The following is a description of a gene set: Human Gene Set: DESCARTES_FETAL_EYE_PDE11A_FAM19A2_POSITIVE_CELLS Marker genes curated from the annotated cluster as represented in the Descartes Human Gene Expression During Development database. from publication Cao J, O'Day DR, Pliner HA, Kingsley PD, Deng M, Daza RM, Zager MA, Aldinger KA, Blecher-Gonen R, Zhang F, Spielmann M, Palis J, Doherty D, Steemers FJ, Glass IA, Trapnell C, Shendure J (PMID 33184181) species: Homo sapiens The gene expression program underlying the specification of human cell types is of fundamental interest. The study authors generated human cell atlases of gene expression and chromatin accessibility in fetal tissues. For gene expression, the study authors applied three-level combinatorial indexing to >110 samples representing 15 organs, ultimately profiling ~4 million single cells. The study authors leveraged the literature and other atlases to identify and annotate hundreds of cell types and subtypes, both within and across tissues. Our analyses focused on organ-specific specializations of broadly distributed cell types (such as blood, endothelial, and epithelial), sites of fetal erythropoiesis (which notably included the adrenal gland), and integration with mouse developmental atlases (such as conserved specification of blood cells). These data represent a rich resource for the exploration of in vivo human gene expression in diverse tissues and cell types., and this is the list of marker genes: FAM163A, SLC26A5-AS1, LTK, ENSG00000262999, RNU7-99P, ANKRD20A8P, SLC10A4, ITPKA, PDE11A, SYT6, RELN (reelin), HDC, PRLR, FRMD7, RGS4, ANKRD20A4P, RNU6-457P, ENSG00000188897, ADAMTS16-DT, RBFOX1 (RNA binding fox-1 homolog 1), TAFA2, GABRD, SLC18A3, FEZF1-AS1, SOX2-OT, CHAT, ISL1-DT, RGS5, SLC5A7 (NCBI Gene Id 60482)